The following is a description of a gene set: species: Mus musculus from publication Chen Y, Wang X (PMID 31504780) Mouse Gene Set: MIR_7657_3P Genes predicted to be targets of miRBase v22 microRNA mmu_miR_7657_3p in miRDB v6.0 with MirTarget v4 prediction scores > 80 (high confidence targets)., and this is the list of marker genes: Slc6a20b, Tssk2, Ovol2, Cfap90, 2310002L09Rik, Pbxip1, Peli1, Edrf1, Rab1b, Ccser1, Pabpc1, Msl2, Gria1, Mapk6, Dot1l, Fam240a, Vps13a, Chm, Tafa1, Dnm1l, Filip1l, Cntnap4, Ctla4, Cdh11, Eaf1, Rab17, Coch, Atxn1, Hsd17b4, Lrba, Bche, Zfp493, Kansl2, Adcy1 (NCBI Gene Id 52867), Zfp850, Cert1, Aldh3a2, Aicda, Nrep, B3gnt2 (UDP-GlcNAc:betaGal beta-1,3-N-acetylglucosaminyltransferase 2), Slc39a14, Cdkn1b, Phyhd1, Nfam1, Chst2, Gdpd2, Dzip1, Zbtb18, Zfp59, Prrg4, Pcdh15, Dnajc16, Arhgap21, Tyw3, Krt34, Celf4, Ap2b1, Coil, Psmf1, Extl1, Rarb, Svop, Ccn4, Actbl2 (NCBI Gene Id 238880), Sdhaf2, Fbxo41, Arl14epl, Donson, Dapk1 (NCBI Gene Id 76556), Prdx6b (NCBI Gene Id 320769), Plcb2, Chtf8, Med13, Sstr3, Ltbr, Bpifa6, Clic4, Prdm6, Fgfbp1, Gramd2a, Tmem243, Robo4